Given this list of marker genes MAP3K9, RRP36, SYN1, FAM53B, RIMS3, SS18L1, QSER1, MYO19, TBX19, TSPAN18, ADCK1, LPP, ZNF592, RFX4, GPSM3, STK24, CDC14A, OLIG3, TMEM248, ADCY3, APTX, RTL9, ANO3, SEMA6D, LTBP2, DMD, LATS2, FLOT1, DIO1, ATP1B4, EDN3, RHOBTB1, TBC1D22A, CALB2, TMEM37, MBD2, HADHB, BAZ2B, SATB1, HOMER1, TMSB15B, KDM5B, SULF1, SLC30A7, PRKCE, SLC39A9, PRPF3, USP25, MIA3, NMD3, STX1A, TMEM145, CCNE2, SLC34A1, KLF7, DYNAP, ZXDA, NBN, SLC8B1, OPRM1, ALK, JAZF1, NOX4, CLDN23, NFATC2IP, FAM234B, FGF14, ISL1, MTF1 (NCBI Gene Id 4520), TMEM229A, RXFP2, RNF144B, TUBGCP3, HRH4, ABCC5, HIP1R, MPP7, IL24, IGSF3, TRIM35, PLAGL2, DDX60L, SH3BGRL2, KLF3, KLF4, COLCA1, ARHGAP24, YOD1, MBTD1, LGALS8, AFF4, MTCL2, RDX, INSYN2A, MCMBP (minichromosome maintenance complex binding protein), EFNB1, RBPJ, TEP1, ARF4, TIGAR, CYB5R4, THOC2, MAPK10, GLB1L, YWHAH, LMO3, AP1S1, ARHGEF2, PCDH8, ATF6, FIGN, WIPF1, ARHGAP11A, KRTAP24-1, NPHP3, CUEDC1, TMPPE, DENND6A, FRAT2, ABHD4, PITHD1, SIGLEC5, PAK1, UBE2A, TBXA2R, LRP10, PDZD4, COL19A1, C11orf87, PTK2B, SGMS1, BCO2, CYP19A1, DPYSL3, MDM4, NDST1 (NCBI Gene Id 3340), MFSD14A, CXXC1, AHCYL1, CLDND1 (claudin domain containing 1), here is a description of the gene set: Genes predicted to be targets of miRBase v22 microRNA hsa-miR-6809-5p in miRDB v6.0 with MirTarget v4 prediction scores > 80 (high confidence targets). Human Gene Set: MIR6809_5P studied in species Homo sapiens from publication Chen Y, Wang X (PMID 31504780)